The following is a description of a gene set: species: Mus musculus Any process that activates or increases the frequency, rate or extent of cardioblast proliferation in the second heart field. A cardioblast is a cardiac precursor cell. It is a cell that has been committed to a cardiac fate, but will undergo more cell division rather than terminally differentiating. The secondary heart field is the region of the heart that will form the majority of the mesodermal component of the right ventricle, the arterial pole (outflow tract) and the venous pole (inflow tract). Mouse Gene Set: GOBP_POSITIVE_REGULATION_OF_SECONDARY_HEART_FIELD_CARDIOBLAST_PROLIFERATION, and this is the list of marker genes: Tbx1, Eya1, Six1, Tbx5, Gng5